Given this list of marker genes IGFBP3 (NCBI Gene Id 3486), IGFBP4, IGFBP6, IGFBP1, IGFBP5, IGFBP2, IGF2R, INSR (NCBI Gene Id 3643), here is a description of the gene set: Human Gene Set: GOMF_INSULIN_LIKE_GROWTH_FACTOR_II_BINDING species: Homo sapiens Binding to insulin-like growth factor II.